Given this list of marker genes SRCIN1, NFIC, RIMS4, FOXE3, MYOM3, FBN3 (fibrillin 3), MEAF6, DYNLRB1, KLF16, WIZ, COL5A3, NIPA1, JUNB (JunB proto-oncogene, AP-1 transcription factor subunit), PPP1R14B, CELF5, SERTAD2, PROSER3, CBX6, VAMP2, FAM98C, FXR2, NFIX, SALL1, CD7, IGF2, IQSEC2, MED20, PATZ1, ARHGDIA, GNAI2, PLPPR2, DELE1, ZNF385A, TSC1, OTOGL, MLLT11, RPS6KL1, ANKRD40, INAVA, ZBTB7A, SKI, GLT1D1, SHANK1, TUBB4A, SERTAD4, MYOG, FOXJ1, FBRSL1, TCF7L2, GRIN3A (glutamate ionotropic receptor NMDA type subunit 3A), SPATA20, here is a description of the gene set: from publication Chen Y, Wang X (PMID 31504780) species: Homo sapiens Genes predicted to be targets of miRBase v22 microRNA hsa-miR-6885-5p in miRDB v6.0 with MirTarget v4 prediction scores > 80 (high confidence targets). Human Gene Set: MIR6885_5P